Given this list of marker genes ANKRD35, BRK1, PRR11, ATP1A3 (NCBI Gene Id 95633), ZBTB18, ARL4C, KLHL1, DPP10, SMG5, SOX14, TRMT13, POU2AF1 (POU class 2 homeobox associating factor 1), LRMDA, FGF16, PRR34, IP6K3, INPPL1, PFKFB3, RESF1, MAF, CASKIN1, ABL2, PLS3, MYT1, GOLGA1, PAX2, TET2, SGK3, ATG12, SH2D3C, GRB10, ANXA1, MCTS1, CXorf58, HMGN2P46, PCCB, IRS1, TFDP2, TNNC1, BNC2, CYB5D2, GMCL2 (NCBI Gene Id 64396, germ cell-less 2, spermatogenesis associated), GREM1, RORC, MYF6, CDC42EP3, ARHGAP45, HUNK, BASP1, SYVN1, APOBEC2, SPOCK2, SLC12A2, NAV3, TIAM1, KCNH2, CACNA1S, LRGUK, PDGFRA, AGER, TIAL1, NCAM1, PRDM1, CACNG3, TACC1, BACE1, CCN4, DSCAM, HCFC2, NXPH4, PELI2, GAD1, RNASE11, WDR20, CACNB3, CHODL, SALL4, LRRTM3, SKIDA1, TMEM109, APBB1 (amyloid beta precursor protein binding family B member 1), EIF1AD, HFM1, PIK3R3, AHR, UNC13B, ATP6V0A2, ZPR1, POU4F3, UNC79, ALDOC, SSH2 (slingshot protein phosphatase 2), ST3GAL5, NAV2, FLRT1, RAB8A, RFC1 (replication factor C subunit 1), ELOVL5, NOL4, OR2L13, CTSA, PCF11, FERRY3, PPP1R3D, TNS2, NTRK1, STRN3 (striatin 3), PASK, FRMD6, NEURL2, TMEM135, ARHGDIB, MAP1LC3B, GPHN, SEMA4A, HMGN5, ZBTB16, FGF13, SLC26A7, ARHGEF12, USP2, PHC2, EFNA4, MRPL49, ZNF277, EDEM3, UCP3, USF1, TNKS1BP1, SGK2, GPR156, CLPX, TBPL1, CDC42BPA, BCL9, HIF1A, DDIT3, HSPB7 (heat shock protein family B (small) member 7), ACVR2A, PAK3, C1QL1, LINC01597, ZNF414, UBR5, NCOA6, SLC25A14, C1orf122, SH3BP5 (NCBI Gene Id 9467), PLCB2, TGIF2, GALNT15, PPIL4, PTPA, ACACA, BHLHE40, TMEM62, TSHZ3, PLP1, ITPK1, LACRT, CAPN11, COL7A1, FAM193B, POU5F2, FLRT3, RORA, SUGP1, PPM1D, XPO7, TSHZ2, PSME3, PPP2R2B, MEIS2, IL11RA, MAP1A, SPRED1, FAM76A, GRIA1, SHROOM2, EIF4E (eukaryotic translation initiation factor 4E), GCAT, NRXN1, PADI1, MCAM, SSBP4 (single stranded DNA binding protein 4), ANKRD13A, TLE1, PBX3, TMEM125, FAM107A, ELMO1, SUFU (NCBI Gene Id 51684), AP3S1, LIN28A, GNAO1, PPP2R5B, EDA, CHRNE, BRAF, LNPEP, KRT14, ATP2C1, YARS1, GNAQ, NHLH2, IL25, FAM217B, WDR49, SHANK2, ELMO2, IZUMO4, C21orf58, HCN4, ZFHX4, NYX, KCNQ4, MGLL, NRSN1, OFCC1, PARP16, SAMD1, OSBP, STC2, KDM4C, ANKRD12, RAMP2, KPNA4, ATXN7L2, CNOT4, SESN1, GOLGA6A, ASCL1, FITM1, NRGN (neurogranin), CHN2, FILIP1, KLF14, PCDHGC3, SPAG8, LHX9, KRT35, NIN, GPM6A, MAP2, ENTPD7, PSMD1 (NCBI Gene Id 5707), ADAMTSL2, DDX6, NCDN, EIF4ENIF1, KIZ, KCNIP2, SFXN2, CDIN1, HOXA3, SPINK5, DMXL1, FAM91A1, CLTC, AP4S1, GOLGA6L9, SEPHS2, COCH, USP32, NRIP2, TAF5, SMYD1, KCNK10, PAFAH1B1, DOCK4, CPA5, CTSK, SEMA6D, LINC00173, GAB2, AZIN1, MIR9-1HG, SOST, RPS6KB1, ARFGAP2, FOXI1, CBX6, ARPC5, RCOR2, VLDLR, KAT6A, CSF3R, ERLIN1, B3GALT2, MYB, WNT2, MBD6, TPM2, PTGR3, GOLGA2P5, ABRAXAS2, ATP6V0D1, TNIP1, PPP1R1B, SOX2, HES6, NME7, GNL1, TJP2 (tight junction protein 2), SIX5, SDK2, RBX1 (ring-box 1), TMIE, CNTN2, SLC16A6, IKZF5 (IKAROS family zinc finger 5), NIPBL, EN1, EYA4, DOLPP1, ID1, PRICKLE1, PRADC1, LRCH4, ELAVL2 (ELAV like RNA binding protein 2), ADCY8, RNF24, ADAMTS3, UBE3D, MYC, DPF1 (NCBI Gene Id 8193), TTN, MN1, ONECUT2, PIM2, CLIC5, GREB1L, OBSCN, TAB2, SEMA6C, GOLGA4, PITPNB, SREBF2, KCTD8, SPARCL1, SPAG9, PAX3, IL4, KLF5, KITLG, STT3B, WNT10A (Wnt family member 10A), PCDH10, HIC1 (NCBI Gene Id 3090), GATM, BCOR, PLXNA2, UBE2H (NCBI Gene Id 7328), AP1AR, ZC3H18, PITX2, PLAU, DYNC1I2, STX4, MEIS1, SLC35D1, PAX6, CREBRF, HOXA1, PSME3IP1, TLE4, PHF12, TFAP2D, ENTPD1, CRAT, ATP6V1B2 (ATPase H+ transporting V1 subunit B2), DYSF, ZBTB17, YTHDF1, GATA6, CEP57, NEUROG2, IL1RN, DMC1 (NCBI Gene Id 11144), NRF1, EP300, TMEM79, BEND4, CPA4, STK3 (serine/threonine kinase 3), DHX37, HCN1, RLIM, TAFA1, ZP1, RFX3, DOP1A, HLX, H1-0, TXLNG, PRR3, DES, ELF4, ZNF408, MOB3A, POU3F3, TAFA4, VPS18, PCP4, UBE2E4P, P4HA2, GBF1, TOP1, ABHD5, DIO2, SYNRG, TEAD3, TBX2, MAGI3, MIR22HG, CAST, MON1A, POU4F2, RBM39, TUBB4A, ACTL6B, GOLGA8A, DNAH10, RBMS1, ATP1B4, TFAP4, NF2, ITGB6, FASTKD2, MAP3K13, CD47, QRFP, ZNF638, BLTP3A, EVX1, STARD6, SMARCA2, DNAJB5, NR4A3, NLK (nemo like kinase), DMD, KBTBD8, DLL4, ZNF821, ASH1L, NR3C2, KRT9, ABCG4, LSAMP, NRG2, SOX5, PRRT1, FKBP3, CBX4, CDKN2C, CHRNA1, METTL8, FOXP2, SESN2, HDAC6, ITCH, SEL1L3, PCBP4, RSPRY1, GLI1 (GLI family zinc finger 1), PABIR1, G2E3, MAP2K5, NRG1, MTCL2, TRAF3, SKA2, LPCAT3, PDZD7, ZMYND8, CDKN2B (cyclin dependent kinase inhibitor 2B), CYSLTR1, E2F8, SH3D21, CD276, EIF2AK3, DDC, CDC42BPB, LAMA3, SMDT1, C9orf78, WFIKKN2, CALD1, GIPR, APBA1, PTCH1, FAM76B, CRISPLD1, CASK, HOXB2, TNPO1, NOL4L, MYBPC1, WNT4, LINC01567, ARPC1A, SNTG1, EIF5A, PCNT, RBM10, PXMP4, MYLK2, CCT7, ZNF593, ITPRIPL1 (ITPRIP like 1), NCALD, ZZEF1, CHRNB3, RAB1A, HMGN2, TCF7L2, RHOBTB1, LRRTM4, OR8B8, KRTAP17-1, FGF12, FAF1, SHOX2, NSL1, SASS6, IKZF2, ARHGAP1, MTMR3, CEBPB, AKTIP, LCOR, ZBTB11, NEUROD4, ERRFI1, RBBP8NL, MAB21L2, PLEKHA6, GOLGA6L2, PDLIM4, NDST4, SLC38A9, ADRA1B, PTK2B, TBX4, UBXN10, ABTB2, CAV3, HCAR2, RARB, SOX4, H2AZ1, SERBP1, IER5L, EPCIP, MXD4, PACRG, DLST, ESRRG, GTF2H1, LRP6, PRRG4, SLC22A11, NFRKB, R3HDM2 (NCBI Gene Id 51220, R3H domain containing 2), AAR2, CAB39, ARMCX3, COPS3 (NCBI Gene Id 8533), SCFD2, IL16, GRIK1, ZNF281, MED26, WWC1, IGSF21, APLN, MDH1B, HOXA2, BAZ1A, SLC9A9, EML1, GHDC, MXD1, RHOD, LHX6, TTLL11, RUNX1, AK2, DAP3, RIOK3, VIL1, HPS5, RNASE4, FZD9, DARS1, WARS1, FXR1, STX6, MOSMO, KMT2C, EYA2, GOLPH3L, PDLIM1, MINDY1, CAMSAP1, AGTR1, HS3ST3A1, APOO, RSBN1, CHD2, DDX42 (DEAD-box helicase 42), CYRIA, SRPK2 (SRSF protein kinase 2), STK40, PPARGC1A, PPP3CB (protein phosphatase 3 catalytic subunit beta), TBX5, EIF4H, BLZF1, CSPG4, ARHGAP30, MYL1, NXF1, KLF12 (NCBI Gene Id 82238), RAD51AP1, RFTN2, WDR81, LENG9, DHRS3, MAP3K3, NR2E1, VIP, PPP1R7, TAF10 (TATA-box binding protein associated factor 10), PTPN1, JUP, CREBZF, BAD, MITF, RSKR, SRGAP2, AKIRIN2, ACADSB, LHX1, EPHB2, DMTF1, IGF2BP1 (NCBI Gene Id 201194), LIX1, MYOZ2, NPPA, TGIF1, DNAJC1, FBXO16, ZNF570, HCAR3, SUN2, ZSWIM2, TRERF1, ADCY5, YRDC, SCUBE3, SIRT1, NSG2, TRIM55, IRX4, ABHD2, TGFB3, UVRAG, ESRRB, HMGB4, FAM110D, GPR119, GRM6, GNB4, SCML1, USP20, SYTL2, EXTL2, RGS6, NOP56, BANF1, RAB7A, PLSCR3, LDLRAD3, ZC3H13, GRK7, WNK4, PRKN, GPC3, SCGN, SAMD11, MGAT4C, ARL3, KIF1B, PHF20L1, PPP2R5C, DCAF17, DPF3, C12orf42, KRT2, WIPF1, METTL9, CXXC5, RNF14, BMP1, RANBP3L, PIAS1, ARHGAP33, PDZRN4, OLIG2 (oligodendrocyte transcription factor 2), MED13, POU4F1, TGM3, TMEM229B, WNT3, GRIK3, REEP1, MSI2, PCDH17, KCNQ5, TNFRSF19, PTN (NCBI Gene Id 5764), NSD3, PBRM1, BACH2, NFATC4, SPIB, FOXO3, SMOC1, RHOJ, ADCY10 (adenylate cyclase 10), BARX2, GNA13, MAP4K4, UBE3A, ALDH3B1, EPHA3 (EPH receptor A3), CLSTN2, CEP112, JPH1 (NCBI Gene Id 56704), HRAS, PLPPR2, SLIT3, CNOT2, DENND4A, DLL1, EXOC6, VRK1, CABP5 (NCBI Gene Id 56344), PNOC, TMEM154, HINT2, OMA1, HR, DNAJA4, MYCLP1, SPTB, CREBL2, MARK2, MAML2 (NCBI Gene Id 84441), MPPED2, MTSS1, RXRG, TLK2, HIC2, RTRAF, SLC30A4, NCKAP5, TMTC2, OSR1, LNPK, CRH, ETV1, BEST3, R3HDM1, KIFAP3, ST8SIA2, TMEM35A, UBP1 (upstream binding protein 1), TNRC6A, PURA, CAPN6, HIP1, FLT3LG, LMO2, DENND2C, RAC2, SLC25A12, USP15, TUBB2B, ARFGEF1, CRNKL1, HNF1B, CCDC47, DNM3, DDX50, RALBP1, ELAVL4, CISH, LHFPL6, CHMP1B, ODF2, YY1AP1, PRM1, MBNL1, SLC7A11, HMGCS1, CNOT6L, ELK3, KLHL20, ACTR1A, TAOK2, NAA40, DNMT1, AP2M1, SGIP1, C11orf16, LIMK2, NEDD4, TJAP1, PDE1A, EYA1, RBM5, BAZ2A (bromodomain adjacent to zinc finger domain 2A), CREB5, XPO1, CKAP4, NEUROD2, CNTLN, ANKS1B, SLC22A8, TMEM71, CYB5R4, ENPP2, PROK2, ERCC6L2, ASB15, MINDY3, ZNRF1, COL11A1 (NCBI Gene Id 317718), DYNC1I1, PABPN1, PPP3CA, FBXO24, BCL6B, TAAR5, ADGRB3, CAMKK2, PDHA2, NNAT, here is a description of the gene set: Comprehensive identification of all functional elements encoded in the human genome is a fundamental need in biomedical research. Here, we present a comparative analysis of the human, mouse, rat and dog genomes to create a systematic catalogue of common regulatory motifs in promoters and 3' untranslated regions (3' UTRs). The promoter analysis yields 174 candidate motifs, including most previously known transcription-factor binding sites and 105 new motifs. The 3'-UTR analysis yields 106 motifs likely to be involved in post-transcriptional regulation. Nearly one-half are associated with microRNAs (miRNAs), leading to the discovery of many new miRNA genes and their likely target genes. Our results suggest that previous estimates of the number of human miRNA genes were low, and that miRNAs regulate at least 20% of human genes. The overall results provide a systematic view of gene regulation in the human, which will be refined as additional mammalian genomes become available. Genes having at least one occurrence of the highly conserved motif M41 TGACAGNY in the regions spanning 4 kb centered on their transcription starting sites. This matches the MEIS1 transcription factor binding site V$MEIS1_01 (v7.4 TRANSFAC). from publication Xie X, Lu J, Kulbokas EJ, Golub TR, Mootha V, Lindblad-Toh K, Lander ES, Kellis M (PMID 15735639) species: Homo sapiens Human Gene Set: TGACAGNY_MEIS1_01